Given this list of marker genes Gjb2, Gjc2, Gjd3, Gjb6, Gja5, Gjc1, Gja1, Gja6, here is a description of the gene set: Mouse Gene Set: GOMF_GAP_JUNCTION_CHANNEL_ACTIVITY_INVOLVED_IN_CELL_COMMUNICATION_BY_ELECTRICAL_COUPLING species: Mus musculus Any gap junction channel activity that is involved in cell communication by electrical coupling.